Given this list of marker genes PSMA2, MYC, UBB, PSMB7, PSMC1, PSMA5, CBFB, CDKN2A (NCBI Gene Id 1029), KAT2B (NCBI Gene Id 8850), PSMD8, PSMD7, LEF1, PSMA1, CTNNB1, PSMA7, CCN2, PSMB5 (NCBI Gene Id 5693), RPS27A, SPP1, PSMD1 (proteasome 26S subunit, non-ATPase 1), TEAD3, UBA52, CCND1, PSMB1, PSMD14, PSMC5 (NCBI Gene Id 5705), MAML1, SMURF1, UBC, EP300, PSMA4, TEAD1, PSMB6, SMAD3, KRAS, NOTCH1, PSMD11 (NCBI Gene Id 5717), ADRM1, CDKN1A, PSMD13, YAP1, PSMB2, BRD2, PSMD12, SEM1, TEAD4, ZFHX3, BCL2L11 (BCL2 like 11), SMAD4, FOXO3, HDAC4, PSMC4, TCF7, PSMC6, PSMA3, PSMA6, TCF7L2, WWTR1, MAMLD1, PSMC2, RUNX3, CREBBP, MAML2, RBPJ, SRC (NCBI Gene Id 6714), TGFB1, PSMD2, MAML3, ITGA4, MDM2, JAG1, TCF7L1, RORC, RUNX1 (RUNX family transcription factor 1), SNW1, PSMB4 (NCBI Gene Id 5692), SMURF2, PSMB3, HES1, PSMD6, PSMD3, TEAD2 (TEA domain transcription factor 2), PSMC3, TP53, KAT2A, ITGAL, here is a description of the gene set: studied in species Homo sapiens The transcription factor RUNX3 is a RUNX family member. All RUNX family members, RUNX1, RUNX2 and RUNX3, possess a highly conserved Runt domain, involved in DNA binding. For a more detailed description of the structure of RUNX proteins, please refer to the pathway 'Transcriptional regulation by RUNX1'. Similar to RUNX1 and RUNX2, RUNX3 forms a transcriptionally active heterodimer with CBFB (CBF-beta). Studies in mice have shown that RUNX3 plays a role in neurogenesis and development of T lymphocytes. RUNX3 is implicated as a tumor suppressor gene in various human malignancies.<br>During nervous system formation, the Cbfb:Runx3 complex is involved in development of mouse proprioceptive dorsal root ganglion neurons by regulating expression of Ntrk3 (Neurotrophic tyrosine kinase receptor type 3) and possibly other genes. It is not yet known whether RUNX3 is involved in human neuronal development and neuronal disorders.<br>RUNX3 plays a major role in immune response. RUNX3 regulates development of T lymphocytes. In mouse hematopoietic stem cells, expression of Runx3 is regulated by the transcription factor TAL1. RUNX3 promotes the CD8+ lineage fate in developing thymocytes. In the CD4+ thymocyte lineage in mice, the transcription factor ThPOK induces transcription of SOCS family members, which repress Runx3 expression. RUNX3, along with RUNX1 and ETS1, is implicated in regulation of transcription of the CD6 gene, encoding a lymphocyte surface receptor expressed on developing and mature T cells. RUNX3 and ThPOK regulate intestinal CD4+ T cell immunity in a TGF-beta and retinoic acid-dependent manner, which is important for cellular defense against intestinal pathogens. Besides T lymphocytes, RUNX3 is a key transcription factor in the commitment of innate lymphoid cells ILC1 and ILC3. RUNX3 regulates expression of CD11A and CD49D integrin genes, involved in immune and inflammatory responses. RUNX3 is involved in mouse TGF-beta-mediated dendritic cell function and its deficiency is linked to airway inflammation.<br>In addition to its developmental role, RUNX3 is implicated as a tumor suppressor. The loss of RUNX3 expression and function was first causally linked to the genesis and progression of human gastric cancer. Expression of RUNX3 increases in human pancreatic islet of Langerhans cells but not in pancreatic adenocarcinoma cells in response to differentiation stimulus (serum withdrawal). Hypermethylation of the RUNX3 gene is associated with an increased risk for progression of Barrett's esophagus to esophageal adenocarcinoma. Hypermethylation-mediated silencing of the RUNX3 gene expression is also frequent in granulosa cell tumors and has also been reported in colon cancer, breast cancer, bladder cancer and gastric cancer. In colorectal cancer, RUNX3 is one of the five markers in a gene panel used to classify CpG island methylator phenotype (CIMP+).<br>RUNX3 and CBFB are frequently downregulated in gastric cancer. RUNX3 cooperates with TGF-beta to maintain homeostasis in the stomach and is involved in TGF-beta-induced cell cycle arrest of stomach epithelial cells. Runx3 knockout mice exhibit decreased sensitivity to TGF-beta and develop gastric epithelial hyperplasia. RUNX3-mediated inhibition of binding of TEADs:YAP1 complexes to target promoters is also implicated in gastric cancer suppression.<br>RUNX3 is a negative regulator of NOTCH signaling and RUNX3-mediated inhibition of NOTCH activity may play a tumor suppressor role in hepatocellular carcinoma.<br>In addition to RUNX3 silencing through promoter hypermethylation in breast cancer, Runx3+/- mice are predisposed to breast cancer development. RUNX3 downregulates estrogen receptor alpha (ESR1) protein levels in a proteasome-dependent manner.<br>Besides its tumor suppressor role, mainly manifested through its negative effect on cell proliferation, RUNX3 can promote cancer cell invasion by stimulating expression of genes involved in metastasis, such as osteopontin (SPP1). part of: Generic Transcription Pathway Reactome Pathway: Transcriptional regulation by RUNX3